The following is a description of a gene set: Human Gene Set: REACTOME_PTK6_REGULATES_RHO_GTPASES_RAS_GTPASE_AND_MAP_KINASES PTK6 Regulates RHO GTPases, RAS GTPase and MAP kinases studied in species Homo sapiens, and this is the list of marker genes: ELMO2, DOCK1, RAC1, HRAS, BCAR1, ELMO1, KRAS, ARHGAP35, CRK, PXN, RASA1, PTK6, NRAS, RHOA